The following is a description of a gene set: studied in species Homo sapiens Bipolar Cells from publication Hu Y, Wang X, Hu B, Mao Y, Chen Y, Yan L, Yong J, Dong J, Wei Y, Wang W, Wen L, Qiao J, Tang F (PMID 31269016) Human Gene Set: HU_FETAL_RETINA_BIPOLAR, and this is the list of marker genes: SV2B, NRXN3, AGAP1, AIPL1, MIR9-1HG, GPX3, ZNF385B (zinc finger protein 385B), PROX1, CRYBG3 (crystallin beta-gamma domain containing 3), LRTM1, ABCA7 (ATP binding cassette subfamily A member 7), GPM6A, CKB, ST18, GNB3, GRM6, CRYM, SNAP25, PCBP3, KCNMA1, PDC, BTBD8, ATP2B1, NR2E3, SYT1, ANK3, TF, PRDM8, UNC119, ATP1B2, CA10, CRYAA (NCBI Gene Id 1409), CAMK2B, CADPS, PCP2, RIMS2, TRNP1, NFIB, WIF1, CCDC88A, FSTL5, RAX2, SYP, SLC17A7, AANAT, MAP7, MIR124-2HG, VSX1 (NCBI Gene Id 8198), GNG13, TCF4, RP1, RD3, NEUROD1, SLC1A7, SLC4A10, TFAP2B, PLXDC1, NEUROD4, SRRM4, PCBP4, RCVRN, MAP4 (microtubule associated protein 4), TMEM215, CHN2, FAM171B, STX3, CABP2, PLCD4, OTX2, GNAT1, CDHR1, NRL, SAG, CACNA1F, NNAT, KCNV2, CRX (cone-rod homeobox), MEG3, VSX2, MPP4, TMEM176B, FRMD3, MIR124-1HG, MIR9-2HG, PROM1, ROM1, NETO1